Given this list of marker genes DCST1, ATG12, PPARG, SPI1, CD300A, SAMHD1, FOXJ1, INPP5D, PIM1, CD59, METTL3, ALOX15, OLFM4, LGALS1, FAM3A, MIR19B1, SYK, TYRO3, RC3H2, MIR181B1, WDR41, YTHDF3, SPN, IL12B, VSIG4, PSMB4, CD160, CRK, DHX58, NCKAP1L, KLRD1, TREM2, FYN, ISG15 (ISG15 ubiquitin like modifier), NLRP4, RPS19, OAS1, DDX39A, CACTIN, CD46, TRAFD1, KIR2DL4, MIR105-1, LYAR, HLA-E, ATG5, FCRLB, STAT2, NPY5R, DUSP22, CCR2, DUSP10, ASCL2, GNAS, FER, MKRN2, NLRP6, MIR302E, PGLYRP1, PTPRC, SLAMF1, IFI16, CLEC12A, CLEC4G, CD274, C9orf72, CNOT7 (NCBI Gene Id 29883), FCGR2B, TREX1, OTOP1, SMCR8 (NCBI Gene Id 162633), CEP63, CEACAM1, CR2, EIF4E2, HAVCR2, HLA-A, USP38, IL33, JAK3, SFN, COL3A1, NECTIN2, CR1L, GIGYF2, SERPING1, YES1, IFNB1, LGALS9, TIGIT, STAT6, MAPK3, USP5, PARP1 (poly(ADP-ribose) polymerase 1), USP18, PLCG1, NR1H3, SLAMF8, IL4I1, MIR21, SOCS5, IRAK3, FGR, IL27RA, TRIM27, TTLL12, USP15, ENPP3, TBX21, SMIM30, SMAD7, MIR19A, ARG2, IL1RL1, PTPN6, SERPINB9, GRN, HLA-F, ADAR, MAPK14, SRC, YTHDF2, NECTIN4, MASP1, AURKB, MIR6869, NPY, GRB2, SAMSN1, ARRB2, GPR17, GPX1, LYN, TGFB1, PVR, TNFSF4, CD80, FOXP3, PLK2, IL10, TNFAIP3, A2M, DTX4, HCK, IL7R (NCBI Gene Id 3575), BCL6, HLA-B, MUL1, CD55, NDFIP1, TNFRSF14, PARP3, SPINK5 (NCBI Gene Id 50962), IL20RB, ACOD1, SUSD4, IL2, SERPINB4, CD96, HLA-DRB1, ZBTB7B, LOXL3, NR1H2, BANF1, PPP3CB, ANXA1, HLA-G, RC3H1, NLRC5, UFL1, SELENOS, YWHAZ, MIR4691, OAS3, FURIN, PTPN2, DNAJA3, BCR, PSMA1, ZC3H12A, NLRX1, ARG1, IL4R, LILRB4, MICA, PGLYRP3, HLX, PDCD1, XCL1, IFNA2, NMI, NLRC3, LGALS3, HFE, C4BPB, MMP12, PARP14, CLEC12B, TRIM21, AHR, AMBP (NCBI Gene Id 259), ZDHHC18, LILRB1, PGLYRP2, INS, RHBDF2, KLRC1, C4BPA, TNFSF18, CR1, DRD2, IFNL1, STAT5A, FGL2, CD69, here is a description of the gene set: Any process that stops, prevents, or reduces the frequency, rate or extent of the immune response, the immunological reaction of an organism to an immunogenic stimulus. species: Homo sapiens Human Gene Set: GOBP_NEGATIVE_REGULATION_OF_IMMUNE_RESPONSE